Given this list of marker genes MSH2, MSH3, PMS2, MSH6, MLH1, here is a description of the gene set: Diseases of Mismatch Repair (MMR) studied in species Homo sapiens Human Gene Set: REACTOME_DISEASES_OF_MISMATCH_REPAIR_MMR